Given this list of marker genes NTAN1P1, MICAL2, SLC35A3, C1orf159, WHRN, TTC1, C18orf21P1, KRT8P14, KAT8, ATP2C2, SDC4, ZNF174, LINC00676, GFRA4, IL26, MIR5586, BIRC6, GSTO1, MTO1, PEG10, CWC25, SUZ12, OTOG, ZSCAN32, DOCK2 (NCBI Gene Id 1794), DRG2, SLC25A6, ABHD17AP3, CELSR1, FEM1C (NCBI Gene Id 84463), ALDOA, LINC00431, HIVEP3, RNF5P1, SNHG30, ADA, THRA, LINC00452, TRIM15, GJB6, BRWD1, ATF6B, LINC01775, NOL6, SGCE, FRMD7, here is a description of the gene set: Human Gene Set: ZNF529_TARGET_GENES Genes containing one or more binding sites for (ZNF529) in their promoter regions (TSS -1000,+100 bp) as identified by GTRD version 20.06 ChIP-seq harmonization. studied in species Homo sapiens from publication Yevshin I, Sharipov R, Kolmykov S, Kondrakhin Y, Kolpakov F (PMID 30445619)